The following is a description of a gene set: studied in species Homo sapiens Human Gene Set: GOBP_NEGATIVE_REGULATION_OF_BONE_REMODELING Any process that stops, prevents, or reduces the frequency, rate or extent of bone remodeling., and this is the list of marker genes: CLDN18, GPR137B, CARTPT, FSHR, P2RX7, UBASH3B, TMEM119, SFRP1, CD38, GREM1, CALCA, IL6 (NCBI Gene Id 3569), IAPP, CSK, TNFAIP3, GPR137, INPP5D